Given this list of marker genes PODXL, P2RX5, FGFR3, BAG3 (NCBI Gene Id 9531), ILF3, TUBGCP4, NCKAP1, H1-10 (H1.10 linker histone), FASN, AKR1C3, NEFH, PRKRA, INPP1, SF1, SCARB1, HOXC10, PIR, WIPF1, ZNF580, UBE2E3, EPHX1, PTBP1, HSPD1, DPAGT1, MAML1, CHN1, ARHGDIA, GSTM4, SF3A2, GNAS, SORD (NCBI Gene Id 6652), NELL2, CTSD, STAT1, DNAJB1, DUSP14, TMPRSS3, SRRM1, OPN3, CTSC, HOXC6, GTF3C3, ATP5MC3, SLC29A2, FBLN1, EMP2, HIRA, PNMA1, PGD, LGALS3BP, S100A4, FHL1, IGF2R, NQO1 (NAD(P)H quinone dehydrogenase 1), ASS1, CALM3, CD44, LGR5, CCDC6, SLCO4A1, HSPA1B, AGPS, ITGAV, EIF4G1, SERPINH1, HSPA1A, MYC, ANXA6, APOBEC3B, TFAP2C, UCK2, INHBC, DGCR2, TXNRD1, TUBA1A, AKR1C1, NFE2L2, SLCO3A1, ID2, NAB1, ICAM1, FBN2 (fibrillin 2), FZD2, MAPRE2, TYRO3, HSPE1, UGDH, CHERP, RBPMS, F8A1, ABI2, HNRNPA3P1, PRKCSH, HYOU1, C1S, SLC29A1, GCLM, ALDH3A1, SF3B1, HNRNPA0, SPON2, MTX2, SKP2, SIX2, TRIM16 (tripartite motif containing 16), C3, AKR1C2, CLU (NCBI Gene Id 1191), EEF1A2 (NCBI Gene Id 6669), GLUL, here is a description of the gene set: Genes up-regulated in the Ad/AH cells (adenocarcinoma) engineered to stably express the Epstein-Barr virus (EBV) gene EBNA1. species: Homo sapiens Human Gene Set: WOOD_EBV_EBNA1_TARGETS_UP The Epstein-Barr virus (EBV)-encoded EBNA1 protein is expressed in all virus-associated tumors where it plays an essential role in the maintenance, replication and transcription of the EBV genome. Transcriptional profiling of EBNA1-expressing carcinoma cells demonstrated that EBNA1 also influences the expression of a range of cellular genes including those involved in translation, transcription and cell signaling. Of particular interest was the ability of EBNA1 to enhance expression of STAT1 and sensitize cells to interferon-induced STAT1 activation with resultant enhancement of major histocompatibility complex expression. A negative effect of EBNA1 on the expression of TGFbeta1-responsive betaig-h3 and PAI-genes was confirmed at the protein level in EBV-infected carcinoma cells. This effect resulted from the ability of EBNA1 to repress TGFbeta1-induced transcription via a reduction in the interaction of SMAD2 with SMAD4. More detailed analysis revealed that EBNA1 induces a lower steady-state level of SMAD2 protein as a consequence of increased protein turnover. These data show that EBNA1 can influence cellular gene transcription resulting in effects that may contribute to the development of EBV-associated tumors. from publication Wood VH, O'Neil JD, Wei W, Stewart SE, Dawson CW, Young LS (PMID 17486072)